The following is a description of a gene set: The chemical reactions and pathways involving an alpha-amino acid. Human Gene Set: GOBP_ALPHA_AMINO_ACID_METABOLIC_PROCESS studied in species Homo sapiens, and this is the list of marker genes: ICMT, AZIN1, HMGCL, PYCR2, DAO, P4HB, GLS, ASNSD1, CDO1 (cysteine dioxygenase type 1), HNF4A, TYR, AMDHD1 (NCBI Gene Id 144193, amidohydrolase domain containing 1), BAAT, BCAT2, AMT, APIP, SARDH, NAT8L, SLC7A7, RIMKLA, GLUL, DGLUCY, SEPHS1, DDAH2, CRYM, GLDC, DLST, KMO, RIMKLB, CPS1, GCLM, IDO2, MTHFD1, UROC1, MPST, ALDH18A1, SLC39A8, ENSG00000274276, ALDH4A1, AGMAT, HMGCLL1, EGLN2, ARG2, HIBADH, MCCC1, HPD, GLYATL1, SMS (NCBI Gene Id 6735), SERINC3, NOS1, FTCD, GOT1L1, HSD17B10, PYCR1, SLC7A11, CARNMT1, PLOD2, ART4, CBS, KYNU, GLS2, THNSL2, PCBD1, BHMT2 (betaine--homocysteine S-methyltransferase 2), BCKDK, NOS2, FAH, SEPHS2, MECP2 (NCBI Gene Id 8274), PRODH2, HAAO, ALDH8A1, NAGS, PSAT1, IDO1, ARHGAP11B, GCLC, HAL, OCA2, MTHFR, IVD, BLOC1S6 (NCBI Gene Id 26258), MSRA, ADHFE1, ACAT1, CTH, MIR21, GSTZ1, ADSS1, GOT1, UCP2, PLOD3, TAT, NOX4, PAH, ATCAY, CARNS1, ASRGL1, AGXT2, MCCC2, SCLY, HGD, SLC45A2, AUH, MTHFS, DAOA, KYAT3, FPGS, TTC36, GAD2, GGT1, HYKK, HIBCH, AGXT, DPEP1 (dipeptidase 1), AADAT, ASPG, ATP2B4, ALDH6A1, ASS1, DDAH1, MTR, PHGDH, GCSH, ARG1, ADI1, BLMH, PRODH, GOT2, SDSL, NR1H4, OTC, HNMT, SRR, ENOPH1, HDC, PARK7, NIT2, LGSN, KYAT1, ACMSD, NOS3, QDPR, GAD1, GCDH, NDP, SDS, PIPOX, HAO1, CAD, GNMT, DCT, ACAD8, PSPH, OAT, MMUT, CSAD, GLUD1, PFAS, RIDA, GPT2, PYCR3, GLYATL1B, GLUD2 (glutamate dehydrogenase 2), CLN3, MTRR (NCBI Gene Id 4552), SERINC5, DDO, SIRT4, GCAT, ATP7A, SHMT2, ALDH5A1, GLYAT, TDO2 (tryptophan 2,3-dioxygenase), ASNS, AASS, MAT1A, FH, ATF4, AZIN2, SLC38A8, IYD, SHMT1, SLC25A21, THAP4, SLC25A2, ASPA, IL4I1, HOGA1, BHMT, TH, ADSS2, AFMID, ODC1, ACADSB, NADSYN1, BPHL, ASL, NOXRED1, GPT